The following is a description of a gene set: from publication Petersen BC, Budelsky AL, Baptist AP, Schaller MA, Lukacs NW (PMID 22543263) species: Homo sapiens Genes down-regulated in comparison of eosinophils treated with IL25 versus neutrophils treated with IL25. Many symptoms associated with allergic asthma result from the sequelae of type 2 inflammation. Interleukin (IL)-25 promotes type 2 inflammatory responses, and T2M cells represent an IL-4 and IL-13 producing granulocytic IL-25 responsive population. We used microarrays to characterize the gene expression profile of T2M cells, and compared T2M cells to other inflammatory subsets (eosinophils, neutrophils, and macrophages) in the lungs of mice with IL-25-induced pulmonary inflammation. Human Gene Set: GSE36392_EOSINOPHIL_VS_NEUTROPHIL_IL25_TREATED_LUNG_DN, and this is the list of marker genes: EIF3E, IFT56, IDH3G, HUWE1, MNAT1 (NCBI Gene Id 4331), MLH3, PREP, IL6ST, CELF4, LONP1, RCC2, MLEC, GJB2, DDOST, MAPK1, PRXL2B (peroxiredoxin like 2B), RPL26, CGNL1, FAM117B, TRIM36, ARMC1, RSL24D1, PIAS2, TRIM3, HSPD1, CDCA3, PEBP1, AP2M1, JARID2, MVP, RCOR3, NSA2, COPG2, PPRC1, GTF3C3, CALHM2, FUT1, PALLD, LCMT1, PRPS2, IL4I1 (interleukin 4 induced 1), ARHGAP31, EXT1, MT2A (metallothionein 2A), TMA16, NDUFA1, RPS7, SNRNP25 (small nuclear ribonucleoprotein U11/U12 subunit 25), AGFG2, NDUFB2, UBR7, NLE1, ETFDH, ALG5, ALPK1, RCBTB1, RPL27, SIAE, FGF13, FAM227B, HADHA, STK25, FIZ1, SMARCA4, NOL6, ACOT7, RPL41, DHRS3, PCDHB7, MRPL24, ARL4C, C3AR1, RNF123, SLC38A9, RAB22A, GPATCH4, CDR2, FYTTD1, NELFA, ILVBL, RPL3, LYPLA1, DUSP22, CORO1C, CBX5, B3GNT7, RFNG, PRC1, HSPA9, HSP90AB1, GATAD1, TM9SF4, MEMO1, C19orf47, EIF4E3, KCNAB2, SLC6A8, EEF1G, DPP9, MCPH1, YWHAE (NCBI Gene Id 7531), SLC5A2, MPND, PARP1, PA2G4, SNRPD2, GMPPA, S100A4, MRPL2, VCP, GLUD1, CD2AP, RANBP1, DNAJC7, CYC1, EIF2B2, OTOG, RPL34, CYB561D2, DPYSL2, SKIC3, CCDC91, NGFR, ALDH1B1, SELENOW, GPR107, TBC1D13, ANAPC5, MMP19, IDH3A, DNAJB14, MARS1, C1QBP, POLR2I, DTWD1, ARSI, TIFAB, COA8, CHST7, ZPBP, POLR1A, SULT1A1, CNIH1, DRG1, RNF150, PES1, PPP2R5C, CCT7, IGF1, MYC, TLE6, LANCL1, BORA, SYNPO, PRDX2, CHURC1, RHOU, GSTM4, MED16, RBM12, BUD23, BOD1, CFDP1, COPZ2, NDUFS5, MYEF2, NIBAN2, KIF20A, DEPTOR, LSM4, CCT5, CYBB, PRKCZ, ERP29, SF3A3, NUDT9, NDUFB10, DDRGK1 (NCBI Gene Id 65992), TRIP10, IRF8, LGALS1, PPP5C, TNPO3, PLAU (plasminogen activator, urokinase), BCL2, SDC1 (syndecan 1), DUS1L, PSMA7, BLTP3A, SCARB1, COQ6, PTPRO, C15orf40, ARL4A, PAGR1, NEXMIF, YBX1, FAM220A, GFER